The following is a description of a gene set: species: Mus musculus Mouse Gene Set: REACTOME_FRUCTOSE_METABOLISM Fructose metabolism, and this is the list of marker genes: Aldob, Glyctk, Aldh1a1, Khk, Tkfc, Akr1b1, Sord